The following is a description of a gene set: Human Gene Set: HP_ABNORMAL_CIRCULATING_HORMONE_CONCENTRATION Concentration of a hormone in the blood circulation outside of normal limits. studied in species Homo sapiens Abnormal circulating hormone concentration, and this is the list of marker genes: PDE6B, AMHR2, CYB5A, PCSK1, UCP2, HACE1, TRAPPC11, SDHB, PRCD, GMPPA, SEMA3A, TMEM127, MRPS22, IFT172, SPAG17, SDHC, PWRN1, SLC7A14, TAF4B, PAX8, NKX2-1, USP9X, QRSL1, LHX4, RP9, VDR, NSMF, PDE11A (phosphodiesterase 11A), LIN28B, AHI1, NR2E3, CASR, EYS, MOV10L1, XRCC2, KCNJ11, ROM1, PDE6A, CDKN2B, MAGEL2, PLAAT3, GNRHR, AIRE, KLF11, CLDN19, INSR, CYP17A1, NPAP1, DUOX2, TOPORS, PDE4D, OCRL, TRHR, VHL, BNC1, RPE65, TPO, NLGN3, CDKN2A, GLUD1, CIDEC, ARHGEF18 (NCBI Gene Id 85008, Rho/Rac guanine nucleotide exchange factor 18), ARL3, ATRX, MRAP, HSD11B1, BMPR1B, OCA2, FMR1, RNU4ATAC, PRPH2, SNORD116-1 (NCBI Gene Id 100033413), NANOS1, KLHL10, GNAS, FIGLA, FBXO43, HPGD (NCBI Gene Id 3248), CERKL (ceramide kinase like), GNRH1, KDM6A, TG, ERCC6, IMPG1, DIAPH2, FGF17, DHH, ARL2BP, ABCD1, PIK3CA, CAVIN1, LEPR, WDR11, ADORA2A, KIAA0753, HGSNAT (heparan-alpha-glucosaminide N-acetyltransferase), CFAP418, MKRN3, CEP112, IGF1R, ALG8, ARMC5, BBS2, DSG1, SLC34A3, TUB, TBX1, MAP3K1, NRL, KIAA1549, MCM8, SDHA (NCBI Gene Id 6389), NR3C1, PRPF8, ANOS1, SMARCB1, NUP107, CFTR, CCDC141, TP53 (NCBI Gene Id 7157), IGSF1 (immunoglobulin superfamily member 1), RET, AKT1, HSD3B2, IDH3A, BSCL2, MCTP2, FOXE1, PSMB8, TTC8, STAT5B, PRPF4, CYP21A2, CDC73, CRB1, CATIP, RP1, NHLH2, PCARE, DIS3L2, KIZ, AGPAT2, GCGR, SNORD115-1, ZNRF3, USP48, PROKR2, GLI2, IL17RD, ADCY3, PHOX2B, SYCP3, RPL10L, NR2F2, CDKN2C, FOXA2, TSHR, DNHD1, SLC39A4, SMC5, FAM20A, FOXL2, MECP2, FSHB (NCBI Gene Id 2488), USP8, GATA4, TP63, RLBP1, NKX2-5, MSH5, PLVAP, IMPG2, SIK3, PRPF31, GCNA, KMT2D, SAG, YY1, LHB, RP2, NEK2, OFD1, MSH4, POMC, KISS1, POU1F1, DCAF17, PNLDC1, BANF1, TRAF7, DUSP6, FGF8, ZFP57, CYP11B1, CCND1, PRPF3, IFT88, RPGR, TRMT10A, NEUROD1, CTDP1, ZNF408, GATC, CDKN1A (NCBI Gene Id 1026), BMP15, SUFU, INS, POMGNT1, DLST, AIP, GLIS3, GUCA1B, RDH12, MAFA, TXNRD2, GDF9 (growth differentiation factor 9), ESR1 (NCBI Gene Id 2099), PMM2, SPRY4, GPR101, NDN, RGR, NNT, RBM28, TDRD9, BAP1, ROBO1, TEX11, BRAF, CYP24A1, CYP11A1, CEL, IMPDH1, BLK, MEIOB (meiosis specific with OB-fold), CRX, DHX37, TERT, PROP1, DNA2, ALB, NF1, FN1, CYP27B1, NR0B1, SERPINA6, SNRPN, GCK, PROK2, DBH, PDGFB, HFE, CPE, OTX2, CBX2, SRY, SOHLH1, IDH3B (NCBI Gene Id 3420), AGBL5, CLRN1 (clarin 1), GCM2, ZFPM2, IGF1, CT55, NDNF, ABCC8, DUOXA2 (dual oxidase maturation factor 2), RP1L1, LMNA, POLR3H, PLAGL1, NSMCE2 (NSE2 (MMS21) homolog, SMC5-SMC6 complex SUMO ligase), MANF, NRAS, LRAT, SMO, PAPPA2 (NCBI Gene Id 60676), MPV17, DHX38, CTSK, AHR, ZSWIM7, CMPK2, CAV1, ANKH, NF2, SPIDR, SECISBP2, CYP11B2, SMARCE1, SLC34A1, LHCGR, MARS2, B4GALNT1, TAC3, MC4R, KISS1R, FAM111A, MRPS7, FGD1, MAK, HS6ST1, SCAPER, SEC61A1, GNAQ, CNGB1, SHOC1, PROM1, MCM9, BEST1, PPARG, DHDDS, THRB, RNU4-2, CDHR1, STX16, CNGA1, POLR3A, SPATA22, MYCN, RNF212, KCNJ6, WT1, NFKB2, FSCN2, PRDM13, HSD11B2, AAAS, KASH5, HTR1A, SNRNP200, RAP1B, ARMC12, PNPLA6, GNAS-AS1, SLC25A36, POLA1 (NCBI Gene Id 5422), PGM1, HYMAI, SEMA4A, ESR2, MC2R, PWAR1, CYP3A4, TBCE, SPATA7, PAX4, RHO, MCOLN1, PDX1, SYCP2L (synaptonemal complex protein 2 like), PRKACA, PRPF6, MIR140, MERTK, REEP6, STAT6, CDH23, WWOX, FSHR, NLGN4X, CCDC134, PRKAR1A, SLC5A2, SLC25A11, APPL1, CLDN16, VAMP7, NAB2, CCDC34, ALMS1, FOS, GALT, PDGFRB, MPI, BMP6, SMARCAL1, TEX14, MAB21L1, STAG3, SOX9, TULP1, MED12, AVP, ZNF513, CNBP, FH, TDO2, CA4, LHX3, COL2A1, GALK1, AR, IRS4, CC2D2A, SOX3 (NCBI Gene Id 8256), PDHA2, RBP3, THPO (NCBI Gene Id 84434), PTH, CYP2R1, CREBBP, HROB, HNF1A, ZMPSTE24, TRPV6, FANCI, RNF125, IGFALS, SLC35C1, CLPP, BTG4, KL, LMO1, PHEX, SLC30A7, MDH2, SOST, WNT4, GHRHR, ADAT3, HFM1, PCYT1A, MAP2K1, IYD, GATB, DNAH10, HSD17B4, GHSR, SAMD9, SLC35A2, FGFR1, ALK, TBL1X, MPDU1, TACR3, MEN1, TEX15, SLC16A2, LEP, KCNJ18, IFT140, FOCAD (NCBI Gene Id 54914), AKT2, ABCA4, HADH, STAR, EPAS1, FAM161A, ALG6, ZMYND15, GLI3, FKBP6, SLC5A5, TERB2, PSMC3IP, LIPE, ARL6, KDM1A, THRA, HESX1, PLIN1, PDE8B, PDE6G, FEZF1, TSHB, FANCM (FA complementation group M), MADD (NCBI Gene Id 8567), HERC2, SLC16A1, GHR, DMXL2, SOX10, KIF1B, DCC, KLHL7, ALG12, UMOD, CDKN1B, SMPD1, SHROOM4, SIM1, TBX19, LARS2, LGR4, DIO1, AMH, NR5A1, SLCO2A1, CHD7, TERB1 (telomere repeat binding bouquet formation protein 1), SDHD, PPP2R3C, FLRT3, MAX, PRNP, POR, C14orf39, EPO, TMEM67, EIF2B1, CTNNB1, SDHAF2, BBS1, USH2A, SH2B1 (NCBI Gene Id 25970), SYCE1, HNF4A, GH1, MYT1L